Given this list of marker genes RASAL1, PSMD8, RASA1, PSMB7, PSMD12, PSMB5, NRAS, SPRED1, RBX1, PSMD3, PSMB4, RASAL2, PSMA5, PSMA6, SPRED3, UBB, PSMC6, SYNGAP1 (NCBI Gene Id 8831), PSMA1, KBTBD7, DAB2IP, PSMC2, RASA2, KRAS, PSMA4, PSMB3, PSMA2 (proteasome 20S subunit alpha 2), PSMD13, RASA4, PSMC5, HRAS, PSMD14, PSMC1, NF1, SEM1, PSMD2, UBC, UBA52, PSMD11, PSMD7, PSMB6, RASAL3, PSMC4, RASA3, PSMA7, PSMA3, RPS27A, SPRED2, PSMB2, CUL3, PSMB1 (NCBI Gene Id 5689), PSMC3, PSMD6, ADRM1, PSMD1, here is a description of the gene set: The intrinsic GTPase activity of RAS proteins is stimulated by the GAP proteins, of which there are at least 10 in the human genome. part of: RAF/MAP kinase cascade species: Homo sapiens Reactome Pathway: Regulation of RAS by GAPs